The following is a description of a gene set: Human Gene Set: PID_ALPHA_SYNUCLEIN_PATHWAY species: Homo sapiens Alpha-synuclein signaling from publication Schaefer CF, Anthony K, Krupa S, Buchoff J, Day M, Hannay T, Buetow KH (PMID 18832364), and this is the list of marker genes: TOR1A, PARK7, HCK, SRC, UCHL1, MAPK3, UBE2L3, BAD, GRK5, LYN, SNCA, MAOB, CSNK2A1, PLD1, FYN, KLK6, SYK, PTK2B, MAPK1, PRKCD, TH, PPP2R5D (NCBI Gene Id 5528), BLK, LCK, FKBP1A, STUB1, PLCB2, PRKN, SLC6A3, PLD2, YES1, FGR